The following is a description of a gene set: Nucleotide (purine) biosynthesis. species: Homo sapiens Human Gene Set: MODULE_102, and this is the list of marker genes: NME1, IMPDH2, UMPS, ADA, NME4, PRPS2, ADSL, GMPS, DTYMK, PAICS, ADK, CTPS1, NME2, APRT, PRPS1, CMPK1, HPRT1, GART, MTHFD1